The following is a description of a gene set: Mouse Gene Set: GOBP_PROTEIN_ACETYLATION The addition of an acetyl group to a protein amino acid. An acetyl group is CH3CO-, derived from acetic acid. studied in species Mus musculus, and this is the list of marker genes: Nat8b-ps, Pml, Arid5a, Kat5, Dip2a (NCBI Gene Id 78897), Kif3a, Bmal1, Naa80, Hint2, Bloc1s1, Esco1, Nat8f1, Naa12, Shh, Dip2b, Naa50, Sox4, Naa16, Gtf2b, Kat2b, Dscc1, Smo (smoothened, frizzled class receptor), D1Pas1, Nat10, Ddx3x (NCBI Gene Id 236681), Bag6, Sphk1, Cep295, Hdac2, Sirt1, Gsk3b, Klf15, Naa11, Kat2a, Esco2, Kat6a, Taok1, Ing5, Crebbp, Sirt3, Prkaa1, Park7, Naa60, Clock, Prkaa2, Nupr1, Ing4, Atat1, Naa15, Fcor, Ep300, Naa10, Nat8f7, Smc5, Aanat, Fam161a, Kat7, Nfe2, Naa20, Xbp1, Nat8, Ankrd11